Given this list of marker genes Ceacam12, Tigd4, Oit3, Hebp2, Ranbp3l, Treh, Bbx, Sgcb, Trpc1 (transient receptor potential cation channel, subfamily C, member 1), Ssxb2, Phf14, Ifi203, Asxl2, Pp2d1, Ccl21d (C-C motif chemokine ligand 21D), Mcur1, Ccl21a, Zfhx3, Htr1f, Hhex, Rai2, Nr5a2, Ccl21b, H2-Q4, Rufy2, Ssxb9, Tnrc6c, Sec24d, Rap2c, Nat8f6, Adgrf5, Ssxb10, Nat8f7, Gins2, Nat8f3, Ssxb1 (NCBI Gene Id 67985), Ifi207, Fank1, 5730480H06Rik, Ccng2, Ccl21e, Cdh9, Ccl21f, Kpna3, Itga2b, Ppfia1, Zpbp, Fndc3b, Arhgap44, Atl3, Kifbp, Zfp597, here is a description of the gene set: from publication Chen Y, Wang X (PMID 31504780) Genes predicted to be targets of miRBase v22 microRNA mmu_miR_6973b_5p in miRDB v6.0 with MirTarget v4 prediction scores > 80 (high confidence targets). species: Mus musculus Mouse Gene Set: MIR_6973B_5P